The following is a description of a gene set: RHO GTPases Activate NADPH Oxidases species: Homo sapiens Human Gene Set: REACTOME_RHO_GTPASES_ACTIVATE_NADPH_OXIDASES, and this is the list of marker genes: NCF1, PRKCZ (NCBI Gene Id 5590), MAPK11, RAC2, PIK3C3, MAPK1, S100A8, NOXO1, MAPK3, PRKCA, NOX1, MAPK14, S100A9, PRKCD, RAC1, PRKCB, NOX3, CYBA, PIK3R4, NCF4, CYBB, NOXA1, PIN1, NCF2